The following is a description of a gene set: species: Mus musculus Mouse Gene Set: GOMF_UBIQUITIN_LIKE_PROTEIN_CONJUGATING_ENZYME_ACTIVITY Isoenergetic transfer of a ubiquitin-like protein (ULP) from one protein to another molecule, usually another protein, via the reaction X-SCP + Y = Y-SCP + X, where both the X-SCP and Y-SCP linkages are thioester bonds between the C-terminal amino acid of SCP and a sulfhydryl side group of a cysteine residue., and this is the list of marker genes: Ube2frt, Ube2u, Ube2l6, Ube2k, Ube2c, Ube2g1, Ube2q2, Ube2h, Aktip, Cdc34, Atg3, Ube2t, Ube2z, Ube2r2, Ube2b, Ube2v1, Ube2l3, Cdc34b, Ube2srt, Taf1, Ube2o, Ube2ql1, Ube2s, Ube2dnl1, Ube2w, Ube2q1, Birc6, Ube2g2, Ube2n, Ube2e3, Ube2d1, Ube2q2l, Ube2j2, Ube2j1, Ube2dnl2, Atg10, Ufc1, Ube2d4, Ube2m, Ube2e2, Ube2f, Ube2d2b, Ube2i, Ube2d2a, Ube2e1, Ube2d3, Ube2a